The following is a description of a gene set: Attachment of GPI anchor to uPAR species: Mus musculus Mouse Gene Set: REACTOME_ATTACHMENT_OF_GPI_ANCHOR_TO_UPAR, and this is the list of marker genes: Pigu, Pigk (NCBI Gene Id 66613), Pigs, Pigt, Plaur, Pgap1, Gpaa1